The following is a description of a gene set: electronically inferred by orthology from the curated human pathway species: Mus musculus Reactome Pathway: Signaling by Nuclear Receptors part of: Signal Transduction This event has been computationally inferred from an event that has been demonstrated in another species.<p>The inference is based on the homology mapping from PANTHER. Briefly, reactions for which all involved PhysicalEntities (in input, output and catalyst) have a mapped orthologue/paralogue (for complexes at least 75% of components must have a mapping) are inferred to the other species., and this is the list of marker genes: Cyp26a1, H4c18, Cav2, Ncoa1, Ptk2, Gng5, H3c10, Calm1, Mmp2, Akr1c13, Kdm1a, H2bc15, Polr2f, Dlat, Gng10, H4c9, H4c8, Cbfb, Akr1c21, H4c1, Polr2a, Ppid, Gtf2f1, Dhrs4, Pdpk1, Med1, H3c13, Gata3, Usf2, Polr2e, H2bc9 (H2B clustered histone 9), H3c2, H2bc3, Tbp, Aldh1a2, Gnai1, H2bc27, Gng3, Gps2, Cyp26b1, Hspb1, H2bc13 (NCBI Gene Id 319185), Foxa1, Fkbp4, H2bc1, Hras, H3c7, Gtf2a1, H3c6, Akr1c14, Hdac3, H4c11, Pdk4, Gng4, Dhrs3, Gnat3, H4c6, Gng11, H3c3, Strn, Gtf2f2, Akr1c20, Fabp5, Zdhhc21, Adh4, Pik3r2 (phosphoinositide-3-kinase regulatory subunit 2), Ppp5c, H2bc7, Dld, Rxrg, H2bc8, Aldh8a1, Polr2b, H2bc11, Gnb2, Polr2k, Pdha1, Mmp3, Cav1, Epgn, Rdh5, Rarg, Shc1, Aldh1a3, Ep300, Dhrs9, H3c1, H4c2, Polr2c, Sdr16c5, H3c8, Mmp7, H2bc22, Pdk2, Erbb4, Btc, H4c14, Xpo1, H4c17, H3c15, H4c12, Rxrb, Cdkn1b (NCBI Gene Id 12576), Akr1c18 (aldo-keto reductase family 1, member C18), H3c4, S1pr3, Polr2l, Gng8, Esr2, Gnb3, Polr2i, H3f3a, Rara, Areg, Kat5, Mapk3, H2ac1, H3c11, Gngt1, Rarb, Cited1, Esr1, H2bc12, Egfr, Gngt2, Tbl1x, H4c4, Ncor2, Carm1, Tgfa, Crabp1, Zdhhc7, Gng7, Abca1, Gnb5, H4c3, Akr1c6, Rdh10